Given this list of marker genes PIAS3, POLR2A, ADTRP, TSC22D3, GRSF1, ZFYVE1, SPOUT1, LRRC47, USP25, SLC22A23, DHDDS, SMYD4, NAA25, C9orf40, NUDT18, CHST14, TNFAIP1, NELFA, CYP27B1, PXYLP1, KAT6B, PTCD1, RIC8A, PRC1, NAP1L5, LXN, WDR55, SIN3A, MRPL49, ADAM19, PEX14, SKP2, FSTL1, PRKAR2B, SYNPO2, OGFOD1, TM4SF1, TOGARAM1, TMUB2, CTC1, MIS18BP1 (NCBI Gene Id 55320), ZNF77, MYH11, USP53, SEMA3C, FDXACB1, P2RY8, ZFP1, MYH10, CRAMP1, MUTYH, CEP55, MTMR4, FBXL20, ELP2, YPEL5, EPB41L4A, WHAMM, TFB2M, TTC5, SLCO5A1, CASP6, CCNL2, SIMC1 (SUMO interacting motifs containing 1), LY75, RELL1, STIL, JPT2, INPP5E, ARHGEF18, H4C8, MBOAT2, PEDS1, NAP1L4, PHF13, NFE2L1, RNF2, LIN52, EPDR1, RPL23AP7, RANBP3, ZNF22, DIPK1A, RPUSD2, KLF6, RHEBL1, MCAM, FANCL, PRKRIP1, FAM222B (family with sequence similarity 222 member B), TWSG1, HENMT1, TRAF5, GLT8D1, FOXP1, DNAJC9, PPARG, VAPA, SFRP4, GCSAM, KLF5, JADE3, HEXIM2, CSTA (cystatin A), KIAA0319L, ATG16L1, PNMA1, CASP9, FAN1, KIF3A, DVL2, FEN1, RAB23, LRRC8D, CENPL, AVEN, PPP1R26, ARHGAP45, COMMD2, REPIN1, SNX11, BDP1, VPS33B, TMCC3, KIF2A, SUPT3H, EXOSC2, GGH, CLUAP1, RALGAPA2, OFD1, POT1, AGK, H2BC5, ZNF43, RAP2B, MACIR, DEPP1, EZH1, TMEM41A, FERMT2, TBC1D4, LRRC1, CRACD, INSM1, EHHADH, PATZ1, DDX11, RBM4B, SETD6, ERLIN1, CXorf58, TWIST1, CASC3, RAD50, NBPF10, TMEM268, BSPRY, AGFG2, NSD3, BRD8, SNHG1, TIAL1, SIK2, NUB1, HEMK1, C12orf76, IPCEF1, CYB5A, CDC16, CEP68, MAPK8, HMMR, ZNF444, TBC1D13, FAM118A, RUFY3, TSPAN13, SLC9B2, FOXO1, EEF1AKMT3, AHR, RAB3IP, PSTK, ENTHD1, ITFG1, MKRN2, LTV1, RAC1, N4BP2L1, AUH, ENTPD7, NMRK1, MRPS6, THAP11, FLT3, HSD17B1 (NCBI Gene Id 3292), ACTMAP, here is a description of the gene set: Human Gene Set: GSE14000_4H_VS_16H_LPS_DC_TRANSLATED_RNA_DN from publication Ceppi M, Clavarino G, Gatti E, Schmidt EK, de Gassart A, Blankenship D, Ogola G, Banchereau J, Chaussabel D, Pierre P (PMID 19943945) Genes down-regulated in comparison of polysome bound (translated) mRNA in dendritic cells (DC) at 4 h after LPS (TLR4 agonist) stimulation versus those at 16 h after the stimulation. Dendritic cells (DCs) are the sentinels of the mammalian immune system and they undergo a complex maturation process mediated by activation upon pathogen detection. Recent studies described the analysis of activated DCs by transcriptional profiling, but translation regulation was never taken in account. Therefore, the nature of the mRNAs being translated at various stages of DC activation was determined with the help of translational profiling, which is the sucrose gradient fractionation of polysomal-bound mRNAs combined to microarrays analysis. Total and polysomal-bound mRNA populations were compared in immature (0h) and LPS-stimulated (4h and 16h) human monocyte-derived DCs with the help of Affymetrix microarrays. Biostatistical analysis indicated that 296 mRNA molecules are translationally regulated during DC-activation. The most abundant biological process among the regulated mRNAs was protein biosynthesis, indicating the existence of a negative feedback loop regulating translation. Interestingly, a cluster of 17 ribosomal proteins were part of the regulated mRNAs, indicating that translation may be fine-tuned by particular components of the translational machinery. Our observations highlight the importance of translation regulation during the immune response, and may favour the identification of novel gene clusters or protein networks relevant for immunity. Our study also provides information on the possible absence of correlation between gene expression and real protein production in DCs. species: Homo sapiens